The following is a description of a gene set: Medullary breast cancer (MBC) is a rare but enigmatic pathologic type of breast cancer. Despite features of aggressiveness, MBC is associated with a favorable prognosis. Morphologic diagnosis remains difficult in many cases. Very little is known about the molecular alterations involved in MBC. Notably, it is not clear whether MBC and ductal breast cancer (DBC) represent molecularly distinct entities and what genes/proteins might account for their differences. Using whole-genome oligonucleotide microarrays, we compared gene expression profiles of 22 MBCs and 44 grade III DBCs. We show that MBCs are less heterogeneous than DBCs. Whereas different molecular subtypes (luminal A, luminal B, basal, ERBB2-overexpressing, and normal-like) exist in DBCs, 95% MBCs display a basal profile, similar to that of basal DBCs. Supervised analysis identified gene expression signatures that discriminated MBCs from DBCs. Discriminator genes are associated with various cellular processes related to MBC features, in particular immune reaction and apoptosis. As compared with MBCs, basal DBCs overexpress genes involved in smooth muscle cell differentiation, suggesting that MBCs are a distinct subgroup of basal breast cancer with limited myoepithelial differentiation. Finally, MBCs overexpress a series of genes located on the 12p13 and 6p21 chromosomal regions known to contain pluripotency genes. Our results contribute to a better understanding of MBC and of mammary oncogenesis in general. from publication Bertucci F, Finetti P, Cervera N, Charafe-Jauffret E, Mamessier E, Adélaïde J, Debono S, Houvenaeghel G, Maraninchi D, Viens P, Charpin C, Jacquemier J, Birnbaum D (PMID 16651414) Genes down-regulated in medullary breast cancer (MBC) relative to ductal breast cancer (DBD). Human Gene Set: BERTUCCI_MEDULLARY_VS_DUCTAL_BREAST_CANCER_DN species: Homo sapiens, and this is the list of marker genes: PTPN21, LINC03072, MYH10, NCOA1, MTSS1, ENSG00000278932, SRPX2, CARMN, DNAAF9, MPRIP, EXTL2 (exostosin like glycosyltransferase 2), CHMP3, TGFB1I1, ZNF727, HSPG2, FBXW2, BOC, FBXO32, SPOCK1, ACSL3 (NCBI Gene Id 55484), LIMS2, PDE5A, EFNA3, VSNL1, RGS5, EDN2, TTC3, EPHA3, ANO1, LGALSL, RCAN1, LGR6, FAP, TPM2, ZCCHC24, FAM210B, GPC1, SPEG, DACT3, NME7, PERP, SNRPN, TAGLN, MXRA7, BGN, ACTN1, FLNA, ZNF20, H4C12, CEP41, LAMA2, LMCD1, KIDINS220, SNAI2, CX3CR1, THBS4, CTNND2, PALM2AKAP2, MAGI3, SLIT3, TMEM134, NDUFV1, EMC3, MSRB3, DDR2, TMEM192, ATP13A4, AQP1, CNN2, CNIH3, AOPEP, DIPK1B (divergent protein kinase domain 1B), MYLK, TTC28, PARVA (parvin alpha), TOP6BL, NPR2, RGS4 (regulator of G protein signaling 4), CADM1, FERMT2, SNHG14, CACHD1, ACTG2, RIT1, UACA, PRICKLE1, IRAG1, ELAPOR2, ADAM12, COPZ2, NAV3, CAPN2, KATNAL1, NPR3 (NCBI Gene Id 79614), ZBTB43, ADAMTS12 (NCBI Gene Id 81792), SPRED2, RTN4 (reticulon 4), MYL9, ACTA2, KLHDC10, MMGT1 (NCBI Gene Id 93380), PPP1R1B, LSP1P5, SMTN (NCBI Gene Id 6525), PTPN14, MBOAT2, ERBB4, CCDC15, DLC1, AOC3, CD81, TMEM61, TLN2, CAVIN1, APBA1, FLNC, VPS37D, TUBG2, NORAD, AGPAT2, MXRA8, CBR3-AS1, FHL1, ITGB5, FKBP9, ZNF385D, PLSCR3, SLC4A3, MYH9, KANK2, GSTA1, KCTD1, GUCY1A2, EFR3B, RFLNB, COPS8, RABGAP1, H3C4, SH3PXD2A, AHNAK, SNX21, SEMA5A, H19, ENPP1, CAPN5, NOSTRIN, ATL1, LIN28A, SORT1, ACVR1 (activin A receptor type 1), CARD19, CALD1, MAPK7, MDFI (MyoD family inhibitor), ENDOD1, SAV1, STARD13, ZFYVE1, GTF2I, RUNX1, CNPY4, FSTL1, TIMP3 (TIMP metallopeptidase inhibitor 3, NCBI Gene Id 7078), SLX4IP, DDAH1, PCDH18, COL8A1, PDGFD, DAAM1, PTPRZ1, PICALM, CAV1, KCNMB1 (potassium calcium-activated channel subfamily M regulatory beta subunit 1), SMIM10L2A, H2AC6, EDNRA, OBSL1, H4C8, H2AC8, ZNF426, C1orf116